Given this list of marker genes SEC16B, GBF1, SEC16A, LRRK2, BCAP29, MIA2, BCAP31, MIA3, CRYZL2P-SEC16B, here is a description of the gene set: Human Gene Set: GOBP_PROTEIN_LOCALIZATION_TO_ENDOPLASMIC_RETICULUM_EXIT_SITE A process in which a protein is transported to, or maintained in, a location at an endoplasmic reticulum exit site. studied in species Homo sapiens